The following is a description of a gene set: studied in species Homo sapiens part of: Diseases of Base Excision Repair Reactome Pathway: Defective Base Excision Repair Associated with MUTYH MUTYH gene is located on chromosome 1 and encodes a DNA glycosylase involved in base excision repair (BER). MUTYH (MYH) functions as an adenine DNA glycosylase and removes adenines and 2-hydroxyadenines on the newly synthesized DNA strand mispaired with guanines or 8-oxoguanines. 8-oxogunanines are produced by oxidation of guanines in DNA or by incorporation of 8-oxodGTP from the nucleotide pool into the newly synthesized DNA strand. Germline mutations in MUTYH cause the MUTYH-associated polyposis (MAP), a syndrome that resembles the familial adenomatous polyposis (FAP) syndrome, caused by mutations in the APC tumor suppressor gene. MAP is also known as the familial adenomatous polyposis 2 (FAP2) (OMIM:608456). MAP-affected individuals are predisposed to development of multiple colorectal adenomas and colorectal cancer. MAP is largely inherited in an autosomally recessive manner, with both MUTYH alleles affected. The predisposition of heterozygous MUTYH mutation carriers to MAP has not been completely ruled out.<br><br>MUTYH is most frequently affected by missense mutations in MAP patients, with two major mutations, Y165C and G382D, reported in about 80% of MAP patients of European origin. In Japanese patients, the most frequently reported mutation was Q324H. In addition to the isoform MUTYH alpha-3, the other two abundant MUTYH isoforms are MUTYH beta-3 and MUTYH gamma-3, which differ from MUTYH alpha-3 in the first exon used. Exons 1-alpha and 1-beta contain sequences that resemble a mitochondrial targeting signal (MTS). It was reported that MUTYH alpha-3 and MUTYH beta-3 predominantly localize to mitochondria, while MUTYH gamma-3 predominantly localizes to the nucleus. However, a nuclear localization signal is located at the C-terminus of all MUTYH isoforms and other studies suggested that all isoforms can localize to the nucleus and only a small fraction of MUTYH is targeted to the mitochondria. A small number of functional studies of MUTYH mutants uses the MUTYH isoform gama-3. Nuclear localization of MUTYH may be affected by a splicing site variant.<br><br>MAP, compared with APC-associated FAP, is characterized by a later age of onset and a smaller number and size of polyps. Germline MUTYH mutations are associated with an increased incidence of duodenal polyps, gastric cancer, melanoma, breast cancer, dental and dermoid cysts, and osteomas. MUTYH mutations are rarely reported in the sporadic colorectal cancer. Tumors that develop in MAP patients are characterized with an excess of G:C -> T:A transversions in tumor suppressor genes, such as APC, and oncogenes, such as KRAS, which is a consequence of MUTYH functional impairment.<br><br>A single nucleotide polymorphism (SNP) at the splice donor site was reported to affect translation efficiency of MUTYH transcript, but its relevance for cancer predisposition has not been clarified. Catalytic activity of MUTYH and its mutants may be affected by posttranslational modifications. Some MUTYH mutations reported in colorectal cancer do not affect MUTYH catalytic activity but disrupt the interaction of MUTYH with other proteins involved in DNA repair.<br><br>For review, please refer to Chow et al. 2004, Nielsen et al. 2011, Venesio et al. 2012, Mazzei et al. 2013., and this is the list of marker genes: MUTYH (NCBI Gene Id 4595)